Given this list of marker genes Klf6, Junb, Ppp1r15a, Tsc22d3 (TSC22 domain family, member 3), Uba52, here is a description of the gene set: Genes negatively differentially expressed in cell type: CD4+ T cell upon treatment with cytokine: IL-22 in mouse lymph nodes in vivo. Mouse Gene Set: CUI_T_CELL_CD4_IL22_RESPONSE_DN from publication Cui A, Huang T, Li S, Ma A, Pérez JL, Sander C, Keskin DB, Wu CJ, Fraenkel E, Hacohen N (PMID 38057668) studied in species Mus musculus Cytokines mediate cell-cell communication in the immune system and represent important therapeutic targets. A myriad of studies have highlighted their central role in immune function, yet we lack a global view of the cellular responses of each immune cell type to each cytokine. To address this gap, the authors created the Immune Dictionary, a compendium of single-cell transcriptomic profiles of more than 17 immune cell types in response to each of 86 cytokines (>1,400 cytokine-cell type combinations) in mouse lymph nodes in vivo. A cytokine-centric view of the dictionary revealed that most cytokines induce highly cell-type-specific responses. For example, the inflammatory cytokine interleukin-1β induces distinct gene programmes in almost every cell type. A cell-type-centric view of the dictionary identified more than 66 cytokine-driven cellular polarization states across immune cell types, including previously uncharacterized states such as an interleukin-18-induced polyfunctional natural killer cell state.